Given this list of marker genes IL1RAPL1, DAG1, PTPRD, IL1RAP, FARP1 (NCBI Gene Id 10160), EFNB3, TENM2, here is a description of the gene set: Human Gene Set: GOBP_TRANS_SYNAPTIC_SIGNALING_BY_TRANS_SYNAPTIC_COMPLEX Cell-cell signaling between presynapse and postsynapse mediated by a trans-synaptic protein complex. studied in species Homo sapiens